The following is a description of a gene set: Genes up-regulated in MEF cells (embryonic fibroblast) isolated from HRAS knockout mice. studied in species Mus musculus from publication Castellano E, De Las Rivas J, Guerrero C, Santos E (PMID 16909116) Mouse Gene Set: CASTELLANO_HRAS_TARGETS_UP We characterized differential gene expression profiles of fibroblast cell lines harboring single or double-homozygous null mutations in H-ras and N-ras. Whereas the expression level of the individual H-, N- and K-ras genes appeared unaffected by the presence or absence of the other ras loci, significant differences were observed between the expression profiles of cells missing N-ras and/or H-ras. Absence of N-ras produced much stronger effects than absence of H-ras over the profile of the cellular transcriptome. N-ras(-/-) and H-ras(-/-) fibroblasts displayed rather antagonistic expression profiles and the transcriptome of H-ras(-/-) cells was significantly closer to that of wild-type fibroblasts than to that of N-ras(-/-) cells. Classifying all differentially expressed genes into functional categories suggested specific roles for H-Ras and N-Ras. It was particularly striking in N-ras(-/-) cells the upregulation of a remarkable number of immunity-related genes, as well as of several loci involved in apoptosis. Reverse-phase protein array assays demonstrated in the same N-ras(-/-) cells the overexpression and nuclear migration of tyrosine phosphorylated signal transducer and activator of transcription 1 (Stat1) which was concomitant with transcriptional activation mediated by interferon-stimulated response elements. Significantly enhanced numbers of apoptotic cells were also detected in cultures of N-ras(-/-) cells. Our data support the notion that different Ras isoforms play functionally distinct cellular roles and indicate that N-Ras is significantly involved in immune modulation/host defense and apoptotic responses., and this is the list of marker genes: Gfer, Nnat, Prdx2, Gnb1, Hoxc8